Given this list of marker genes PRH1, VCAM1 (NCBI Gene Id 7412), BOC, CRB1, H4C8, UTS2B, ISL2, TEX38, FOXF1, NRG3, MZF1-AS1, ZFP37, METTL16, TPBG, TSHZ3 (NCBI Gene Id 91672), TRPM4, SPEM2, MYO5C, APCDD1, ARSD, PTPRZ1, CMBL, AQP2, GRIN2C, SNX12, ALDH7A1, SLC1A1 (NCBI Gene Id 6505), TSPAN9, RAI14 (retinoic acid induced 14), MST1, KRT2, FATE1, FKBP7, RAX, SLC5A11, AQP7, ENC1, RASIP1, CAV1, ZBTB11-AS1, HOXB13, SLC8A1-AS1, TXLNB, CEP170, P2RX1, HPR, SCRN1, FOXQ1, PAK6-AS1, KIAA1549, CSHL1, LDHC, ZNF527 (zinc finger protein 527), KIR3DX1, MIR622, DMRTB1, ARHGAP20, ACSM2A, AGT, VWA7, SH2D4B, DAND5, TCF21, LINC03043 (long intergenic non-protein coding RNA 3043), MACROD2-AS1, KCNQ5, ZKSCAN2, KRT19 (keratin 19), HRH2, LHFPL3, SLC24A1, LINC01093, PCDHA2, FRMD4B, FCRL3, FBXO30, COX7A1, PROK2, KLHL11, CCR3, RBPJ, IL1A, SMPX, PPP2R2B, PRIMA1, SUMO2, PAPLN, CYP2A6, PPIAL4A (NCBI Gene Id 653505), ASB11, TTLL4, EMSY, DISP2, LIPJ, PCAT18, HSD3B2, HAO1, USP45, SHTN1, TRPC2, SPMAP1, CACNA1B, LINC00648, DUOX2, SHISA3, SLC38A11, LMAN1L, CYP2E1, PDK4, PKD1L1-AS1, ALDH1L2, ZNF596, DOLK, LINC01220, PLCB3, MIR503HG, NES, RASSF9 (NCBI Gene Id 9182), LINC01096, ZSWIM5, ANK3 (ankyrin 3), KLF8 (KLF transcription factor 8), NPY4R, PPEF2, TMEM54, POU4F2, FMNL2, ZNF221, ARRDC4, USP43, PRSS55, ARHGEF28, PAPOLA-DT, H4C9, ARID1A, RDUR, OMG, MTMR7 (NCBI Gene Id 9108), GPR26, DDO, ZNF630, KRTAP2-3, STUM, FNDC9, SOX17, CCDC168, KRT81, JPH3, LRRTM2, TAF4B, HTR5A, INPP5J, ABCA8, CALHM5, SLC7A14, STRIP2, DMBX1, CLIC2, KCNH3 (NCBI Gene Id 23416), NKAIN4, LINC02112, TWIST2, NTN1, DCAF8L2, STX1B, ARHGAP28, FIZ1, TREX2, PDZK1, TTLL7, LINC00862, CYP7B1, ITLN1, SCN10A, DIO3OS, ZBTB20-AS1, TAF1L, IRX3, KREMEN1, F2RL2, LRRC58, ZC2HC1C, CSN1S1, ZFP42, SMIM10, SPEF1, CFAP410, CYP46A1, here is a description of the gene set: Human CD14 positive monocytes were purified from healthy volunteers’ blood and cultured in vitro for 4, 12, 24, 72 hours. While culturing, macrophages were activated alternatively with interleukin-4 (IL-4 100 ng/ml) or classically with interferon-gamma (IFNg 100 ng/ml)+tumor necrosis factor (TNF 50 ng/ml) or left without activation. Simultaneously, macrophages were also treated with vehicle (DMSO:ethanol) or 1mM synthetic PPARg agonist, Rosiglitazone. We used Affymetrix microarrays (U133Plus 2.0) to analyze activation and PPARg-induced gene expression changes. from publication Szanto A, Balint BL, Nagy ZS, Barta E, Dezso B, Pap A, Szeles L, Poliska S, Oros M, Evans RM, Barak Y, Schwabe J, Nagy L (PMID 21093321) species: Homo sapiens Human Gene Set: GSE16385_UNTREATED_VS_12H_ROSIGLITAZONE_TREATED_MACROPHAGE_UP Genes up-regulated in macrophages (12h): control versus rosiglitazone.